Given this list of marker genes RSPH3, DNAAF11, MGP, SPEF2, RSPH9, LIG4, CCDC65, FCGR2A, CCNO, CFAP45, TTC12, LRRC56, RSPH4A, DNAH5, DNAAF2, CCDC40, RPGR, CCDC39, DRC1, ZMYND10, DNAL1, CFAP298, PIK3R1, DNAI2, AIRE, ODAD4, DNAAF4, NME5, PIK3CD, CCDC103, HYDIN, ODAD1, MCIDAS, DNAAF1 (NCBI Gene Id 123872), DNAH9, TAP2, RNF168, BLNK, CFAP221, CLXN, DNAJB13, DNAH11, OFD1, DNAH7, SPAG1, TAP1, DNAAF5, FOXJ1, SASH3, CFAP52, CFAP74, DNAI1, NEK10, GAS2L2, CD79B, NME8, CFAP300, IGKC, PTEN, ODAD2, STK36, DNAH1, DNAAF6, DNAAF3, CSPP1 (centrosome and spindle pole associated protein 1), IGHG2, ODAD3, TGFB1, RSPH1, PGM3, CFTR, here is a description of the gene set: A chronic form of sinusitis. Chronic sinusitis species: Homo sapiens Human Gene Set: HP_CHRONIC_SINUSITIS